The following is a description of a gene set: Human Gene Set: GOMF_GROWTH_FACTOR_ACTIVITY species: Homo sapiens The function that stimulates a cell to grow or proliferate. Most growth factors have other actions besides the induction of cell growth or proliferation., and this is the list of marker genes: IL12A (NCBI Gene Id 3592), THPO, TGFB2, AMBN, INHBA, CRIPTO3, NODAL, NENF, LACRT, CSPG5, FGF9, THBS4, JAG2, GDF1, TGFA, FGF8, FGF4, NGF, CD320, GDF5, GDF15, LEFTY1, GFER, VEGFC, GH2, OSGIN2 (NCBI Gene Id 734), LIF, RABEP1, NRG3, ENDOU, CRIPTO, OSM, IGF1, CSH2, IL9, FGF20, NRTN, CXCL1, TYMP, CSF1, IGF2, BMP15, IL6, AMH, GDNF, FGF2, FGF22, BDNF, MIA, PDGFB, PGF, ARTN, F2, GRN, CSH1, JAG1, MACC1, CCN6, FGF7, TFF1, GDF9, GDF2, HBEGF, GH1, GPI, HDGFL3, PPBP, CNTF, INHA, RABEP2, HDGF, FGF12, FGF16 (fibroblast growth factor 16), AMELX, IL4, FGF1, BTC, EREG, FGF21, TIMP1, EGF, PROK1, FGF10, GMFG (glia maturation factor gamma), KITLG, FGF14, PDGFA, BMP1, GKN1, IL34, GDF10, CLEC11A, CSF3, OSGIN1, CCN3, CLCF1 (cardiotrophin like cytokine factor 1), IL11, NRG1, EPGN, FGF18, LEFTY2 (left-right determination factor 2), INHBC, VEGFD, FGF13, ADA2, BMP10, FGF11, GDF3, GDF6, DKK1, MANF, BMP6, CDNF, VEGFA, EFEMP1 (EGF containing fibulin extracellular matrix protein 1), PSPN, BMP8B, VGF, IL7, PTN, REG1A, FGF6, GDF7, CXCL12 (C-X-C motif chemokine ligand 12), BMP5, MSTN, IL2, FGF17, TGFB3, HGF, NRG2, CSHL1, GMFB (glia maturation factor beta), NTF3, GDF11, FGF3 (NCBI Gene Id 2248), ANGPTL3, PDGFD, INHBE, BMP4, BMP8A, MDK, VEGFB, CSF2, NRG4, BMP3, BMP7, AREG, IL3, FGF5, IL5, INHBB, FGF23, IL10, NTF4, FGF19, TGFB1, AGT, IL12B, PDGFC, BMP2, OGN (NCBI Gene Id 4969)